The following is a description of a gene set: Dendritic cells (DCs) are the sentinels of the mammalian immune system and they undergo a complex maturation process mediated by activation upon pathogen detection. Recent studies described the analysis of activated DCs by transcriptional profiling, but translation regulation was never taken in account. Therefore, the nature of the mRNAs being translated at various stages of DC activation was determined with the help of translational profiling, which is the sucrose gradient fractionation of polysomal-bound mRNAs combined to microarrays analysis. Total and polysomal-bound mRNA populations were compared in immature (0h) and LPS-stimulated (4h and 16h) human monocyte-derived DCs with the help of Affymetrix microarrays. Biostatistical analysis indicated that 296 mRNA molecules are translationally regulated during DC-activation. The most abundant biological process among the regulated mRNAs was protein biosynthesis, indicating the existence of a negative feedback loop regulating translation. Interestingly, a cluster of 17 ribosomal proteins were part of the regulated mRNAs, indicating that translation may be fine-tuned by particular components of the translational machinery. Our observations highlight the importance of translation regulation during the immune response, and may favour the identification of novel gene clusters or protein networks relevant for immunity. Our study also provides information on the possible absence of correlation between gene expression and real protein production in DCs. studied in species Homo sapiens Genes down-regulated in comparison of polysome bound (translated) mRNA versus total mRNA 4 h after LPS (TLR4 agonist) stimulation. from publication Ceppi M, Clavarino G, Gatti E, Schmidt EK, de Gassart A, Blankenship D, Ogola G, Banchereau J, Chaussabel D, Pierre P (PMID 19943945) Human Gene Set: GSE14000_TRANSLATED_RNA_VS_MRNA_4H_LPS_DC_DN, and this is the list of marker genes: DNAJC15, AMZ2, FGF21, PDE1B, MAP1LC3A, HMGN2, CMPK1, ZNF585A, ST3GAL4, RPLP1, PPDPF, ATP5PF, FNDC8, ELOB, MSANTD3, UBXN2A, RPS14, JPX, MZT2A, ETFRF1 (electron transfer flavoprotein regulatory factor 1), PERM1, PER1, NEDD8, RPP14, HAUS2, BORCS8, NENF, LST1, MOSMO, HP, COX20, FRMPD1, NDUFA2, LINC01588, EEF1B2, EOLA1, H2AZ2, STARD3NL, TMEM147, ROMO1, NDUFB1, RPL22, MANBAL, ORMDL1, HOXB1, CRYM, ZFAS1, SEC11C, UBE2D2, CHGB, AKIRIN1, MRPL23, PTP4A2, C1orf43, MSRA, SNORA71B, CWC15, RAB12, WNT10B, PIGY, SNTA1, ILF3-DT, TMED2, PKIB, TMSB10, EGR4, KATNBL1, ZDHHC4, SMG7, RAB5A, RPLP0, FUOM, UQCR11, CCDC154, SP8, C19orf25, GNG5, NBDY, TNFRSF12A (TNF receptor superfamily member 12A), DAP, RPS17, ZNF510, CD99P1, OR5I1, LINC01101 (NCBI Gene Id 84931), SERF2, CACNG5, PRXL2C, LASP1NB, PNN, RIBC1, NOTCH2NLA, PRMT2, MFAP4, SVBP, ATG5, CDC26, TMEM14B, OST4, SMIM12, UQCRQ, PRELID3B, TMEM230, PNCK, ZNF81, GTF2A2, JAGN1, PDZD8 (NCBI Gene Id 118987), CAPN15, CSNK1E (NCBI Gene Id 1454), PCGF3, PRR4, DLX4, GPX1 (glutathione peroxidase 1), DPH3, MCUR1, C17orf49, ZNF273, PRELID1, PLXNB3, NAXE, EEF1G, PAPOLA-DT, MRPL14, TBPL1, CFAP95-DT, RPS27, NUP210P1, CCNYL1, RBCK1, PTS, COX17, OPN3, CARD19, TMEM184C, NKIRAS2, SLC35B1, VAPB, UBE2Q2, NDUFAF3, PTPRO, SMCO4, EPHA4, DNAJC19, ERBB3, ACVRL1, RARB, POLR2D, GUK1, CHMP6, RAC1, CMC2, LRRC10B, RHOG, KLK14, PARP6, EOLA2, RPL30, GOLGA7, LYPD6B, TPM4, RPP25, KIRREL2, RPL13P5, RHEB, TP53TG1, PPP3R2, PHPT1, SLC66A3, BAG1, LSM12, RPL36, MKKS, BCL7B, RPS28, RAP2A, TAF10, RPL23A, TMEM167A, RAP1A, TRAPPC10, TNNT3, ARL2BP, FOXN3-AS1, CD99, STMP1, RGS10, CIAO2B, SERP1, RPL12, SYNGAP1, NDUFA11, MYOD1, TPT1